The following is a description of a gene set: species: Homo sapiens Human Gene Set: GOBP_REGULATION_OF_PHOSPHORUS_METABOLIC_PROCESS Any process that modulates the frequency, rate or extent of the chemical reactions and pathways involving phosphorus or compounds containing phosphorus., and this is the list of marker genes: SFRP1, ADAR, ARNT (NCBI Gene Id 405), BRAF, XBP1, NPRL2, GIT1, AVPR1B, RASIP1, TRIM27, ADCYAP1, STRADA, KSR1, IL34, FGF16, ADIPOQ, INSM1, MT3, INHA, ZNF16, CD80, PFN2, NPM1, BMP2, EFNA1, MTMR2, STK38, NIBAN1, EGFR, TNFRSF10A, PRKAA2, PLAUR, CIMAP3, HLA-DRB1, FBH1, MLST8, PPP2CA, ACVR2A, PHIP, PDGFRB, XRCC6, RIPK1, S100A12, CALCA, CDK5R2 (cyclin dependent kinase 5 regulatory subunit 2), DBNDD2, CNOT9, PRDX3, PRLR, CD244, BEND3, SNX6, FLCN, IKBKB, PPM1E, WARS1, KIF14, LATS2, PKMYT1, RAF1, ODAM, PARD3, SPDYA, ERBB2, RIPK2, CDC25A, PTPN13, BCKDK, MOB1B (MOB kinase activator 1B), ARHGEF2, YWHAG, LACC1, PDGFA, ENO1, SRCIN1, ADGRF5, MAPK1, JAK2, ADAM17, PARP1 (poly(ADP-ribose) polymerase 1), PARP14, SNCA, ADARB1, MAP3K4, TNFRSF18, EPHA7, GPER1, PDK3, ERCC6, CASS4, ERN1, PTPRC, NSD1, SLC4A1, NEK10, LACRT, TSG101 (tumor susceptibility 101), DOK7, BCCIP, PFKFB1, PDCD10, NOP53, ACTN3, RACK1 (receptor for activated C kinase 1), DMTN, TRIB1, SIRT6, PAQR3, RTRAF, FGF1, TNF, CDKN2A, CDK5RAP1, FZD7, PLEK, GPRC5A, CNTF, FIRRM, GAPDHS, VEGFA, DYNLL1, WDFY2, IL12A, TRAF4, RBL1, VCP, ITLN1, IGF1, EREG, ZFYVE28, ACSL3, MFSD2A, SAMSN1, MIR30C1, RAC1, SNF8, CDK5R1, GNB3, IFNL1, RHOA, NLRC5, P2RX7, ZNF622, DIPK2A, MMD2, BMP4, PINK1, ABCA2, ANG, TAB2, ERBB4, FLT3 (fms related receptor tyrosine kinase 3), PPP2R3C, TSPO, CD300A (CD300a molecule), ATP5IF1, IRGM, HSPB1, MIF, GCK, MMP9, PIK3CG, ABCA3, SMO, SYNPO2 (synaptopodin 2), FGF2, PILRB, TARBP2, IL11, THPO, ALDOB, PLXNB2, HDAC3, SASH1, NT5DC2, HRG, CDKN1C, ITGB2, FBN1, DNAJC30, FBP1, PRKACA, CDC6, CD74, NRG1, SYAP1, CDKN3, LIF, ALS2, IL4, FER (NCBI Gene Id 2241), C9orf72, RAB38, CCDC88A (NCBI Gene Id 731560), TBX1, PTEN, ATPSCKMT, IL21, INHBA, STK11, APOE, MYCNOS, IFNG, FGFR1, RSPO1, CENPE, SCARB1, S1PR2, PIH1D1, VPS25, BCL10, PRKAG2, CEP85, PIN1 (NCBI Gene Id 5300), THBS1, MAPK8IP1, ANTKMT, TPD52L1, APC, SLC2A6, CNKSR3, PKIA, CSF1R, RASSF2, GPLD1, NTSR1, PRXL2C, IBTK, LTF, TRAF3IP1, LDLR, PDCD4, PIBF1, NR1H4, NHERF1, NEDD9, TCIM, STAT3 (signal transducer and activator of transcription 3), MRNIP, DUSP1, CHMP6, NLRP2B, NDUFS4, MACROH2A1, IL15, PTPN2, ROPN1, TP53 (tumor protein p53), ARRB1 (NCBI Gene Id 408), SESN2, TMSB4X, GRB10, CHI3L1, ANGPT4, TAOK3, ZBED3 (zinc finger BED-type containing 3), GSK3A, ACMSD, SNX9, CLSPN, ECT2, CBFA2T3, MAP3K7, RAP2A, IL6, DHX34, TRAF2, RPTOR, SOCS4, CADM4, ARL2BP, KLHL31, KNDC1, AREG, MAP2K2, CDC37, COPS8, GMPPA, CEMIP, GPD1, MAP2K1 (mitogen-activated protein kinase kinase 1), RALB, TNFRSF10B, STRADB, NCOR1 (NCBI Gene Id 9611), PPP1R17, CSPG4, FLT4, NPTN, MTOR, PTK2B, CARD14, DDR2, JTB, HEG1, STK4, ELANE, PIK3R6, ATG14, GLMN, TIGAR, ABL1, TAFAZZIN, ANKLE2, CCNG1, RB1, HGS, MUSK, CORO1C, PHB2, BLM, PDK1, PTPRJ, TNFSF15, ENPP7, MCM7, FGF10, WEE2, CAMK1, SFN, CDK12, C3, TLR3, FAM20A, SOCS5, NDUFC2, PIK3R5, SRC, RASGRP1, DDIT4, GUCA1A, MYDGF, DNAJC3 (NCBI Gene Id 5611), FLOT1, CDKN1B, PRKAG3, PARP9, BANK1, TGFB1, CAMKK2, FLT1, SFRP2, ROPN1L, FGF7, CDK5RAP3, BRAT1, CTF1, SERPINB3, MAP3K11, LPIN1, EP300, PTK6, ME2, ARL2, MTMR1, TARDBP, STOX1, DRD4, SPHK2, HIPK3, ANGPT1, PTPN22, MST1, IL18, EZH2 (enhancer of zeste 2 polycomb repressive complex 2 subunit), SERTAD1, RGS14, RAP2C, LIMCH1, EMP2, NRP1, PRKCD, SMG6, LCP2, SPRY2, SDCBP, CCNE2, ENPP2 (NCBI Gene Id 5168), PROM2, TENM1, MST1R, ZFP91, FKBP8, CHP2, EFNA5, HIF1A, PTH1R, FGR, PRKAA1, GSKIP, SMG5 (SMG5 nonsense mediated mRNA decay factor), INS, SLIT2, APP, TERF2IP, SIRT2, AGAP2, TSPYL2, FN1, CRIPTO, INPP5K, INSR, DSTYK, ZBTB7A, FAM20C, DDRGK1, ADCYAP1R1, P2RY1, CREBL2, UVRAG, INPP5F, TNIK, AGT, HTR2C, MIR675, VEGFB, PDK4 (NCBI Gene Id 5166), GTF2H1, CDC25C, PDGFB, IGBP1 (immunoglobulin binding protein 1), ARHGEF5, LPCAT1, MTCH2, FAXDC2, PIM1, EEF1A2, TREM2, CCNY, UNC119, TOM1L1, RARRES2, SRPX2, PRKAG1, SCP2, MLXIPL, DIRAS2, DUSP7, DEPTOR, PDK2, TRAF6, PRKDC, KAT2B, CCNYL1, GCKR, IGFBP3, RAPGEF2, ABI1, CCNT2, PRKN, TLR6, KIT, DNM1L, APOC2, MAD2L2, AKT1S1, MEN1, TAF7, MTMR3, HES1, FIS1, CACTIN, CHRM5, CLIP3, DYNAP, PYCARD, HERC5, LHCGR, CAB39, BARD1, TPX2, CCNK, ERRFI1, WNT5A, SEMA4D, THBS4, SPHK1, ZNF268, LMO4, P2RY6, ROCK2, RIPK3, DSCAM, LYN, DIRAS1, ZGPAT, MIDN, UCHL1, PPIA, INCA1, GUCA1ANB-GUCA1A, ACP4, CAPN2 (calpain 2), GPRC5B, HNRNPU, OSM, XRCC5, CEACAM1, ADORA1, ITGB1BP1, IL20, CARD10, SIRT1, CDKN1A, IQGAP1, CACUL1, IGBP1C, EPM2A, AKTIP, LAT, APOC1, FABP3, PAK2, DEFB114, WNK3, TNK2, RD3, HTR2A, IER3, DNAJC19, RAP2B, MVP, PTH, FGFR3, GAS6, UBE2K, MAP3K10, EGF, MAP2K3, DIRAS3, CNOT7, ADCY8, LEP, PID1, SPATA18, TRIM6, TNFSF18, ETAA1, AKT1, EIF6, TFAP4, PDCL3, PPP1R15B, TRIB3, TRIB2, ZBTB20, LDB1, PSEN1, ENG, HMGA2, TPK1, FGF18, CDA, PTK2, AIDA, CIB1, ZC3H12A, ADCY10, IDH1, LDB2, APLN, NUPR1, GADD45A, FGF19, RAP1A, RBL2, URI1, RALBP1, DNAJA1, MAP4K2, IL31RA, PRR5L, TRIM63, TREX1, RAD17, KDR, MMD, ARAF, PRKCH, MTMR9, LILRA5, PSMD10, SMG8, HTR2B, JMJD8, HDAC4, CEP43, KDM4D, PELI2, ME1 (malic enzyme 1), SLC4A4, PRKG1, DRD2, CDK2AP1, MAP3K5, CCNT1, KCTD20 (NCBI Gene Id 222658), ROPN1B, LATS1, PTPN1, FBLN1, THY1, SMG7, AMDHD2, NPPA, STAT2 (NCBI Gene Id 6773), PPARA, CD4, PGK1, OGT, CHP1